The following is a description of a gene set: species: Mus musculus Enables the transmembrane transfer of a cation by a voltage-gated channel. A cation is a positively charged ion. A voltage-gated channel is a channel whose open state is dependent on the voltage across the membrane in which it is embedded. Mouse Gene Set: GOMF_VOLTAGE_GATED_MONOATOMIC_CATION_CHANNEL_ACTIVITY, and this is the list of marker genes: Kcnv2, Kcnk1, Calhm1, Trpa1, Kcna7, Kcnk5, Scn2b, Kcnn1, Grin2a, Kcns2 (K+ voltage-gated channel, subfamily S, 2), Kcna3, Cacna2d4, Kcnd1, Cacna1f, Kcnh3, Kcnk16, Kcne2, Catsper1, Cnga2, Kcnb1, Cacna1a, Kcnq1, Kcnn4, Kcnb2, Kcnj2, Kcnj1, Cacng8, Kcna2, Cacnb4, Hcn3, Kcns3, Kcnab3, Kcnh4, Kcnk12, Grm7, Kcnh5, Catsper2, Kcnt2, Kcnq2, Tmc1, Cav1, Cacng3, Kcna10, Cybb, Tpcn2, Kcne3, Kcnq5, Hcn2, Kcne1, Cacna1b, Kcnk3, Cacna1c, Kcna6, Tmem109, Lrrc38, Cacna1s, Kcnh2, Kcnq3, Cacna1g, Cacna1h, Kcnk4, Kcnc4, Pkd2, Kcns1, Kcnj15, Kcne5, Kcnn2, Kcnj13, Kcnk2, Kcnab1 (NCBI Gene Id 16497), Oprm1, Rimbp2, Kcnj3, Lrg1, Kcna4, Kcnk13, Kcng1, Kcnk6, Cacna2d2, Kcng3, Grin2d, Snap25, Lrrc55, Kcne4, Kcnj10, Cacng7, Cacna1d, Cacna1i, Cachd1, Cacnb2, Kcnf1, Kcnt1, Hcn1, Cacna2d1, Cacng5, Kcnma1, Catsper3, Kcnk9, Kcnj8, Kcnj5, Kcnj4, Kcnk10, Lrrc26, Kcnj14, Cacng2, Ryr1, Kcnv1, Kcng4, Grin1, Kcnh6, Kcnk7, Ncs1, Kcnk18, Kcnd3, Kcnh8, Kcnh7, Kcnc1, Kcna1, Cacna1e, Kcnj6, Kcnab2, Kcnj16, Kcnj11, Catsper4, Kcnh1, Kcnd2, Kcnq4, Cacnb3 (calcium channel, voltage-dependent, beta 3 subunit), Tmc2, Htr1b, Tspoap1, Cacng4, Itgav, Kcna5, Kcnj12, Kcnn3, Cacna2d3, Kcnc3, Kcnc2, Hcn4, Lrrc52, Kcnj9, Cacng1, Hvcn1, Kcnip2, Cacnb1